Given this list of marker genes Cytl1, Slc39a8, Ift80, Idua, Mtf1, Comp, here is a description of the gene set: A tissue homeostatic process involved in the maintenance of an internal equilibrium within cartilage, including control of cellular proliferation and death and control of metabolic function. Mouse Gene Set: GOBP_CARTILAGE_HOMEOSTASIS studied in species Mus musculus